The following is a description of a gene set: Mouse Gene Set: CUI_LANGERHANS_IL18_RESPONSE_DN Genes negatively differentially expressed in cell type: Langerhans upon treatment with cytokine: IL-18 in mouse lymph nodes in vivo. from publication Cui A, Huang T, Li S, Ma A, Pérez JL, Sander C, Keskin DB, Wu CJ, Fraenkel E, Hacohen N (PMID 38057668) species: Mus musculus Cytokines mediate cell-cell communication in the immune system and represent important therapeutic targets. A myriad of studies have highlighted their central role in immune function, yet we lack a global view of the cellular responses of each immune cell type to each cytokine. To address this gap, the authors created the Immune Dictionary, a compendium of single-cell transcriptomic profiles of more than 17 immune cell types in response to each of 86 cytokines (>1,400 cytokine-cell type combinations) in mouse lymph nodes in vivo. A cytokine-centric view of the dictionary revealed that most cytokines induce highly cell-type-specific responses. For example, the inflammatory cytokine interleukin-1β induces distinct gene programmes in almost every cell type. A cell-type-centric view of the dictionary identified more than 66 cytokine-driven cellular polarization states across immune cell types, including previously uncharacterized states such as an interleukin-18-induced polyfunctional natural killer cell state., and this is the list of marker genes: Haus8 (4HAUS augmin-like complex, subunit 8), Kctd12, Chka, Tmem176b, Fam53b, Mxd1, Tspan3, Tnfrsf1b, Slc6a6, Icosl